Given this list of marker genes ZSWIM5, ARID1A, KATNBL1, MSRB3, DPH3, SLC30A7, TNRC6B, KCTD5, FAM133B, FBXO33 (NCBI Gene Id 254170), RAB21, IGF1R, SFT2D3, EML5, ZBTB33, PTPN22, CBL, SPTLC2, DHFR (NCBI Gene Id 203373), TEX11, CCR2, MIEF2, HYCC2, CUX1, MTM1 (myotubularin 1), ERP27, TMEM86A, KLF3, NF1, PDLIM4, USP27X, CASK, KLF7, SGPL1, KCNS2, CCDC25, ANKRD44, SLC2A5, UNG, YY1, UNC13C, SYCP1, TMED10, PAFAH1B2, DLG2 (NCBI Gene Id 283225), RAB23, GPD2, NPAS3, BBX, EGLN1, PTF1A, CPPED1 (NCBI Gene Id 55313), INTS7, CDKL5, CNTNAP2, PLPPR1, CDC42BPA, RHOXF2 (Rhox homeobox family member 2), ARRDC3, PPP3CB, OSTF1, NFATC2IP, ANTXR1, HIF1A, ASAP2, REPS2, SERTAD4, RBPJ, CDK12 (NCBI Gene Id 51755), PHACTR2, WRNIP1, TLCD4-RWDD3, CTNND1, CDYL2, PTGFR, NYAP1, EGLN3, NOB1, C1QTNF9, CFAP65, CRISP1, WASHC4 (NCBI Gene Id 23325), FAM171A1, DDHD2, RHOXF2B, ABRAXAS2, MED28, SV2C (NCBI Gene Id 22987), ANAPC7, RCOR1, TLN2, PDZD2, MAP2, PAX7, NOS1, CCNT2, FOXJ3, TNKS, HNRNPH3, GPD1, ATP9A, BRWD1, GNAI1, MED12L, KLC1, DOK1, DSC2, SRPK1, GASK1A, HTR3D (5-hydroxytryptamine receptor 3D), TMTC2, EFCAB14, ACTN2, RAB6B, SLC45A3, MAP3K7CL, SLC1A1, KIF3A, PTPRG, SERINC3, GPM6B, DDX5, WWC2, WNK1, COBLL1, SLC35F1 (NCBI Gene Id 222553), RORA, RIOK3, DUSP22, DCUN1D3, RAPGEF2, FAM133A, DESI2, here is a description of the gene set: Human Gene Set: MIR3128 from publication Chen Y, Wang X (PMID 31504780) studied in species Homo sapiens Genes predicted to be targets of miRBase v22 microRNA hsa-miR-3128 in miRDB v6.0 with MirTarget v4 prediction scores > 80 (high confidence targets).